The following is a description of a gene set: Human Gene Set: GOBP_REGULATION_OF_PHOSPHATIDYLCHOLINE_BIOSYNTHETIC_PROCESS Any process that modulates the frequency, rate or extent of phosphatidylcholine biosynthetic process. species: Homo sapiens, and this is the list of marker genes: CAPN2, RAB38, ACSL3, LPCAT1, FABP3